Given this list of marker genes Abcc3, Abcc6, Ralbp1, Abcc2, Abcc10, Abcc1, Abcc4, here is a description of the gene set: Catalysis of the reaction: ATP + H2O + glutathione S-conjugate(in) -> ADP + phosphate + glutathione S-conjugate(out). species: Mus musculus Mouse Gene Set: GOMF_ABC_TYPE_GLUTATHIONE_S_CONJUGATE_TRANSPORTER_ACTIVITY